Given this list of marker genes EP300, TP53, UBB (ubiquitin B), JMY, SMYD2, EHMT1, UBA52, TTC5, L3MBTL1, UBC, PRMT5, CHEK2, SETD9, ATM, EHMT2, MDM4, RPS27A, MDM2, KMT5A, here is a description of the gene set: TP53 (p53) undergoes methylation on several lysine and arginine residues, which modulates its transcriptional activity.<p>PRMT5, recruited to TP53 as part of the ATM-activated complex that includes TTC5, JMY and EP300 (p300), methylates TP53 arginine residues R333, R335 and R337. PRMT5-mediated methylation promotes TP53-stimulated expression of cell cycle arrest genes. SETD9 (SET9) methylates TP53 at lysine residue K372, resulting in increased stability and activity of TP53.<p>TP53 transcriptional activity is repressed by SMYD2-mediated methylation of TP53 at lysine residue K370. Dimethylation of TP53 at lysine residue K373 by the complex of methyltransferases EHMT1 and EHMT2 also represses TP53-mediated transcription. The chromatin compaction factor L3MBTL1 binds TP53 monomethylated at lysine K382 by SETD8 (SET8) and, probably through changing local chromatin architecture, represses transcription of TP53 targets. The histone lysine-specific demethylase LSD1 interacts with TP53 and represses p53-mediated transcriptional activation. PRMT1 and CARM1 can also modulate p53 functions in a cooperative manner. Reactome Pathway: Regulation of TP53 Activity through Methylation part of: Regulation of TP53 Activity species: Homo sapiens